Given this list of marker genes F2R, MIR17 (microRNA 17, NCBI Gene Id 406952), TGFB1, HIF1A, TIMP1, AGER, IL1A, PPARG, here is a description of the gene set: Human Gene Set: GOBP_CONNECTIVE_TISSUE_REPLACEMENT_INVOLVED_IN_INFLAMMATORY_RESPONSE_WOUND_HEALING The series of events leading to growth of connective tissue when loss of tissues that are incapable of regeneration occurs, or when fibrinous exudate cannot be adequately cleared, as part of an inflammatory response. studied in species Homo sapiens